Given this list of marker genes Eme1, Dnase2a, Gen1, Xrcc3, Mus81, Eme2, Rad51c, Slx1b, Dnase2b, here is a description of the gene set: Catalysis of the hydrolysis of ester linkages within deoxyribonucleic acids by creating internal breaks to yield 3'-phosphomonoesters. studied in species Mus musculus Mouse Gene Set: GOMF_DNA_ENDONUCLEASE_ACTIVITY_PRODUCING_3_PHOSPHOMONOESTERS